The following is a description of a gene set: Human Gene Set: HP_HIGH_PALATE Height of the palate more than 2 SD above the mean (objective) or palatal height at the level of the first permanent molar more than twice the height of the teeth (subjective). species: Homo sapiens High palate, and this is the list of marker genes: HEY2, RPS20, RAF1, POLR1C, ORC4, ERCC4, BCOR, ATG7, SLC6A17, RPL9, SETBP1, SNRPB, FANCE, ESCO2, POLR1B, YWHAE, ZMPSTE24 (NCBI Gene Id 10269), SEC23B, OBSL1, ORC1, LAGE3, KBTBD13, MYOD1, TRIM32, BBS1, FUT8, WBP4, CBS, SMG9, SNX14, ATP6V1E1, COL2A1, TCTN3, DOK7, IFT172, PLAGL1, LTBP1, FBXL3, CEP152, AGRN, DSE, EBP, MYL1, USF3, SLC2A10, REV3L, CFAP418, ATP9A, FAM20C, HNRNPU, USP9X, SCLT1, MT-TE, AP4M1, TTC5 (tetratricopeptide repeat domain 5), RPL18, ANKRD11, PIGV, EFNB1 (NCBI Gene Id 1947), TAF6, ARID1A, GEMIN4 (NCBI Gene Id 50628), RRAS, AP4E1, PEX10, ERLIN2, WASHC5 (NCBI Gene Id 9897), PAH, IGF2, VPS35L, PCDHGC4, IFT140, PRPS1, YARS1, KCNJ6, MYPN, ERCC2, PRKG1, BBS9, MAP2K2, BGN, RPS17, TPM3, MAP3K7, HIVEP2, H19, SOX9, RAB18, SMOC1, FAT4, GMNN, SEC31A, LRP12, AKT1, REEP1, SCN4A, NUP107, TMCO1 (NCBI Gene Id 54499), GJA5, FANCF, SCARF2, MECP2, PEX26, SHH (NCBI Gene Id 6469), HSPA9, BRAF, RUNX2, TRPM3, PTCH1, RPS29, TTC8, PEX12, FBXO11, SHOC2, ANO1, FZD2, SLC18A3, NCDN, TRMU, ADSS1, RFWD3, PEX13 (NCBI Gene Id 5194), SPEG, MYO18B, MAPK8IP3, PPP2CA, AASS, CSNK2A1, ABL1, CNTNAP2, COG1, COPB1, IFT122, CHRNA1, EYA1, FIG4, PMM2, PIGW, GATA1, RECQL4 (NCBI Gene Id 9401), SMAD3, SDHD, KLHL7, VPS13B, CHRNG, DDX59, ADAMTS15, EEF1A2, NOTCH2NLC, LMOD3, B3GALT6, WNT7A, TBX1, EDEM3, MYH3, HEATR3, PEX14, CHKA, WDPCP, BLNK, MYMX, COL3A1, EIF2AK3, RPL26, MINPP1, HECW2, MAP1B, RBM10, SELENON, RIN2, GTF2H5, CDT1, MEG3, QARS1, ATP7A, EFEMP1, AK9, TFAP2A, POLRMT (NCBI Gene Id 5442), CPT2, CLCF1, ERMARD, ZMYM2, PPP1CB, PYROXD1, TET3, DVL1, RUSC2, SET, DHX30, TNNT1, SLC25A1, FANCB, IBA57, PEX6, ZNF292, SCAPER, RAB3GAP2 (RAB3 GTPase activating non-catalytic protein subunit 2), PDZD8, GNPAT, ANK1, FAM149B1, MSTO1, RAP1B, COL11A1, KMT2B, TPM2, THOC2, WNT5A, TBX4, SP7, MED12, SLF2, BBS7, EXOC7, MOGS, KMT2D, POR, NIPBL, SH3PXD2B, LRRC8A, SLC39A7, MAD2L2, RNASEH1, CPSF3, PDE6D, RPS24, CRIPTO, CRELD1, RPS10, RPS27, TAOK1, MFAP5, H4C5, NONO (non-POU domain containing octamer binding), COL6A2, AP1G1, NOTCH3, PIGB, KIAA0753, ADAT3, PIGN, SMCHD1, GJA1, COLEC11, HACD1, VPS51, FANCA, INTU, WDR4, THSD4 (thrombospondin type 1 domain containing 4), POGZ, SLC12A6, DST, POLR1D (NCBI Gene Id 51082), FLNA, GFPT1 (NCBI Gene Id 2673), STAC3, DDHD2, FANCC, COX6A2, KDM6A, ASXL3, SKI, NEK1, UBE3B, MT-TN, STAT3, SPTBN1, COL1A2, PDHX (pyruvate dehydrogenase complex component X), MED12L, SIAH1, MEGF10, PCGF2, LMBRD1, HNRNPH2, EFEMP2, KIF7, NR2F1, TGFBR1, RAB23, AFF4, MYLK, ERI1, EXOSC9, FGFR3, ZNF668, CHST14, SC5D, PGAP3, TRPS1, MTX2, SCNM1, PTEN, ALDH6A1, SIK3, GPT2, MID1, MCM3AP, PIGA, FREM2, BIN1, LMNA, PIK3R1, KCNN3, ARID2, DPM1, QRICH1, RPL35A, TBC1D20 (NCBI Gene Id 170488), BBS4, RRAS2, KLLN, LIG4, SNRPN, CASK, BBS5 (NCBI Gene Id 428), DEAF1, ARCN1, CAMTA1, YY1, SPRED2, GPC4, SMARCB1, SMARCD1, MAT2A, ACTA1, TGFB2 (NCBI Gene Id 7042), BBS10, COL12A1, IFT74, GSC, VAMP1, PIGT, TWIST2, LRP4, MYH2, MYO9A, NDUFAF6, CLP1, DDX6 (NCBI Gene Id 1656), CHRNE, CAMSAP1, CHD3, TTN, HNRNPH1, GNB1, SIX1, MYCN, RERE (NCBI Gene Id 9642), SCAF4, CNTNAP1, TOGARAM1, FRAS1, RILPL1, DDX3X, MAMLD1, NOTCH2, SNIP1, PGM2L1, NRAS, L1CAM, RET, GMPPB, TSR2, KRAS, ALG14, BRCA1, COL6A1, ARL6, PEX2, SHANK3, FOXE3, SDHC, RPS23, CDK19, MAN2C1, RPL11, ATR, UBAP2L, SOX6, PIK3CA, SPRED1, SLC26A2, APC, MYH11, AP4S1, CRKL, FANCI, PIEZO2, NALCN, RAB3GAP1, ATP6V0A2, PAFAH1B1, BMP2, SMC5, TOE1, SCO2, PCLO, CCDC22, HRAS, FANCG, BCR, BLTP1, HBA1, PEX19, DIS3L2, SOS2, FBN2, ASPH, PAX1 (NCBI Gene Id 5075), CREBBP, ADAM22, RPS7, DDR2, XRCC2, ZNF341, PAX7, FBXO28, FOXH1, AEBP1, MARS1, PEX16, ASH1L, GRIP1, ARMC9, ABCC6, CACNA2D1, LAMB2, KCNJ5, OFD1, MRAS, CD79A, NSRP1, HBA2, CLCN3, PLXND1, FANCM (FA complementation group M), HYMAI, CLTC, IGLL1, BBS12, WDR11, BRD4, FRMPD4, FRA10AC1, UBE2T, PEPD, YARS2, TRIP4, ITPR1, TGFBR2, IGBP1, SYT2, CDON, STAG2, ATP6V1A, GIPC1, RPL35, PALB2, SOS1, DISP1, MADD, DPYD, HOXB1, PPP2R5D, DPAGT1, SEC23A, CPLANE1, MED25 (NCBI Gene Id 81857), ELN, CDH2, DCHS1, ZBTB20, FOXP2, OCLN, HNRNPK, SMAD4, SIX3, TMEM231, MYBPC1 (NCBI Gene Id 9116), ANTXR1, HDAC8, ATRX, SPOP, LTBP2, MTM1, KMT2A, TOPORS, CHST3, NEFL, SLC39A13, TAF1, MESD, NAA60, IL6ST, RNF113A, KCNH1, GNB2, SDCCAG8, MAPK1, WDR35 (WD repeat domain 35), SATB2, MPLKIP, SYNGAP1, ECM1, KLHL41, PQBP1, MEGF8, GPC3 (glypican 3), PYCR2, AFG2B, ALG3, CA2, TGDS, SLC25A24, AHDC1, PTPN11, DPYSL5, RRM2B, NUP88, FGFR2 (fibroblast growth factor receptor 2), MYL2, ATP6V1B2, ZC4H2, ERCC3, CTNNB1, HSD17B4, AARS1, RAD51, CHRND, NAA10, MYMK, PSAT1 (phosphoserine aminotransferase 1), CARS1, MRPL12, ARX, TBC1D24, ATN1, NODAL, AMER1, TARS1 (NCBI Gene Id 94887), ATAD1, GATA4, ADA2, CD96, CEP295, PLOD1, ADARB1, CHAMP1, RAD51C, MYL11, PUS1, RASA2, ADNP, GABRA3 (NCBI Gene Id 2556), SEC24D, HERC1, SLC17A5, SRY, TCF3, SLC25A12, GNE, ITGA7, IRX5, STIL, FGFR1, SMC1A, DVL3, COX14, GJA8, CFL2, GTF2E2, PIGL, MKKS, NEK9, SPEN, GBA1, RPL27, FGF8 (fibroblast growth factor 8), MAPKAPK5, PPP1R21, PGAP2, WARS2, CCDC28B (coiled-coil domain containing 28B), GRB10, PEX5, TCOF1, BBS2, NF1, FH, TIMM50, PGM3, UFC1, CHAT, CNOT1, FLNB, TASP1, CCDC47, COLQ, GLI2, COL13A1, SMC3, CDC6, CTSK, KCNK9, ESAM, INSR (NCBI Gene Id 3643), NSD1, PLCH1, TNNT3, RPS6KA3, NSDHL, FN1, OSGEP, TGFB3 (transforming growth factor beta 3), PIGY, RAPSN, HSPG2 (heparan sulfate proteoglycan 2), RPL31, WDR73, UPF3B, MED13L, IFT27, CUL4B, KANSL1, PEX11B, EP300, RAD21, SOX11, ZFX, CDH11, PEX3, COL5A1, RPL8, PUS7, RPL15, EPG5, RPS28, TBCK, MAP3K20, DMXL2 (NCBI Gene Id 23312), AP1S2, HUWE1, SPTAN1, PIGO, COG5, FLCN, FANCL, NDUFA8, LGI4, NUP188, PTPN14, SMARCA2, RNU4-2, PURA, DHPS, CDC45, STAG1, DLL1, CTBP1, TRIP12, SDHB, PAK3, SPI1, RPS15A, BRIP1, ZIC2, EBF3, MAP2K1, SPTBN4, FANCD2, SNAP25, ORC6, BAP1, NFIX, SEMA5A, DPH5, CTU2, ACTA2, TAF4, ALG2, TUBB, OTUD6B, SLX4, TWIST1, RFX7, BRAT1, NPHP1, IL11RA, TBX5, BICRA, DLK1, SLC5A7, HYOU1, CACNA1S, MYH7, PTDSS1, POLR1A, IGHM, IER3IP1, SMAD2, DDX11, PLAA, ARHGEF2, TSPEAR, FGD1, G6PC3, CD79B, BMPR1A, SLC35A2, RYR3, SURF1, TMEM216, EFL1, LETM1, ACTB, PIGU, IPO8, ANOS1 (anosmin 1), RIT1, FBN1, DOCK3, FOXL2, DLG3, CHD6, DPM2, WLS, HPDL, VAC14, KDM5C (NCBI Gene Id 8242), UBA1, TRIO (trio Rho guanine nucleotide exchange factor), CBL, LZTR1, GATAD2B, BMP4, KIF26A, SLC10A7, ANAPC7, RPL5, CNTN1, BBIP1, SMS, AIFM1, MUSK, ASPM (NCBI Gene Id 93990), RPS26 (ribosomal protein S26), TGIF1, IGF1R, PHIP, SIN3A, CEP290, FILIP1, CTNND2, DBH, NSUN2, KCNJ2, EIF4A3, RPS19, LOX (NCBI Gene Id 4015), CHRNB1, POLR2A, PIGH, TUBB3, HPGD, TWNK, SON (NCBI Gene Id 84155), FARSB, PYCR1, SHOX, NKX6-2, BRCA2, CEP19 (NCBI Gene Id 84984), GAS1, LZTFL1, ZNF699, CRLF1, TNNI2, CDK10, RTL1, NRCAM, NEB, PUM1, GLE1, ZBTB24, KPTN, ODC1, AP4B1, TLK2, ARID1B, ZDHHC9, MN1, PRMT7, PEX1, ACTN2, RYR1, MKS1